Given this list of marker genes Pde6a, Prom1, Gnb1, Prph, Cdhr1, Cnga1, Rom1, Pde6b, Prcd, Rho, Gucy2e, Phlpp2, Pde6h, Rdh11, Pde6g, here is a description of the gene set: Mouse Gene Set: GOCC_PHOTORECEPTOR_OUTER_SEGMENT_MEMBRANE species: Mus musculus The membrane surrounding the outer segment of a vertebrate photoreceptor.